Given this list of marker genes DUS1L, TOPORS, CD24 (NCBI Gene Id 934), CCDC86, NT5C, AKIRIN2, ENSG00000260830, SPAG1, SYPL1, SRA1, JAG1, AP1S1, BLZF1, CRK, RIMOC1 (RAB7A interacting MON1-CCZ1 complex subunit 1), STRN3, ARPC2, IMPACT (NCBI Gene Id 55364), JRKL, NDUFV3, GPR87, GULP1, IDI1, GTPBP4, TSC22D3, IRF9, PPP1R9A, TMEM11, ASB3, MYL12B, FAM149B1, ZNF281, KCTD5, TRIM2, TNFRSF12A, PFDN1, TAX1BP3, KPNA5, RP2, STOM, IFIT1, DHX36, SP100, GORAB, ASF1A, ATP6V0E1, ETNK1, LRP10, ST3GAL1, RBM48, ARHGAP12, ADGRF4, UBE2L3, MICOS10, BTBD10, TATDN1, SLC25A25-AS1, YRDC, MBNL1, SRRM1, ATG12, LGALS3, PCDHB3 (protocadherin beta 3), WHAMM, CDIN1, TBC1D9, KLF7, RRAS, STXBP3, PBX2, PDPR, GCA, TIPRL, RNF149, COIL, NDUFB8, SAMD9, PRPF40A, WDR45 (NCBI Gene Id 11152), IFI6, MIR5188 (NCBI Gene Id 100847004), MPZL2, CAPZA2, RNFT1, HNRNPA1, CTSB, SEC23B, PEX1, ZNF292, TUBGCP5, DCAF1, PFDN4, BSDC1, RFC5, NEK7, HNRNPK, FAS, RDH11, ELOA, COPS5, PHF11, ZNF765, SUMO4, RBBP6, PPP1R13L, MYNN, IFRD1, PRIM2, LIN7A, RARS1, CAMK2D, SEC23A, ACBD3, MED13L, SLC25A44, DHRS4-AS1, SREK1IP1, CCT6A, CLIP1, REST, DNTTIP1, RBMY2FP, MTMR2 (NCBI Gene Id 8898), RAD18, DPM1, PAM, GABRR2, CYP20A1 (cytochrome P450 family 20 subfamily A member 1), HBS1L, RRP15, RNF14, SCML2, PCBD2, HINT3, CPE, PAM16, SF3A1, COPG2IT1, CLTA, OCLNP1, DAXX, RCHY1, SPTBN1 (NCBI Gene Id 91654), F12, NSUN4, MEX3C, BCL9L, RAD23B, MSMO1, GADD45GIP1, ATE1, GNA13, RPP30, SERINC3, FARSA, MRPL9, CSRNP1, ZNF91, MRPS11, CHMP5, PGM3 (phosphoglucomutase 3), STAT1, ISG15, ITM2B, TNKS2 (tankyrase 2), UBA3, ACER3, GALNT7, MPLKIP (NCBI Gene Id 136647), DIP2A, NAA35, DUSP3, UBQLN1, CASP9, HMGCS1, LRRFIP1, COBLL1, GATA2, NCOR1, CEBPZ, ELL, JOSD1, DNAJC15, here is a description of the gene set: from publication Wang N, Lin KK, Lu Z, Lam KS, Newton R, Xu X, Yu Z, Gill GN, Andersen B (PMID 17452977) Human Gene Set: WANG_CLIM2_TARGETS_DN species: Homo sapiens Genes down-regulated in MCF7 cells (breast cancer) engineered to conditionally express a dominant negative form of CLIM2 by a Tet Off system. The nuclear LIM-only protein 4 (LMO4) is upregulated in breast cancer, especially estrogen receptor-negative tumors, and its overexpression in mice leads to hyperplasia and tumor formation. Here, we show that deletion of LMO4 in the mammary glands of mice leads to impaired lobuloalveolar development due to decreased epithelial cell proliferation. With the goal of discovering potential LMO4-target genes, we also developed a conditional expression system in MCF-7 cells for both LMO4 and a dominant negative (DN) form of its co-regulator, cofactor of LIM domains (Clim/Ldb/Nli). We then used DNA microarrays to identify genes responsive to LMO4 and DN-Clim upregulation. One of the genes common to both data sets was bone morphogenic protein 7 (BMP7), whose expression is also significantly correlated with LMO4 transcript levels in a large dataset of human breast cancers, suggesting that BMP7 is a bona fide target gene of LMO4 in breast cancer. Inhibition of BMP7 partially blocks the effects of LMO4 on apoptosis, indicating that BMP7 mediates at least some functions of LMO4. Gene transfer studies show that LMO4 regulates the BMP7 promoter, and chromatin immunoprecipitation studies show that LMO4 and its cofactor Clim2 are recruited to the BMP7 promoter. Furthermore, we demonstrate that HDAC2 recruitment to the BMP7 promoter is inhibited by upregulation of LMO4 and that HDAC2 knockdown upregulates the promoter. These studies suggest a novel mechanism of action for LMO4: LMO4, Clim2 and HDAC2 are part of a transcriptional complex, and increased LMO4 levels can disrupt the complex, leading to decreased HDAC2 recruitment and increased promoter activity.